Given this list of marker genes EPHB1, PAX2, CHRNB2, EPHB2, KCNA2, GLI3, here is a description of the gene set: species: Homo sapiens The process in which the anatomical structure of the optic nerve is generated and organized. The sensory optic nerve originates from the bipolar cells of the retina and conducts visual information to the brainstem. The optic nerve exits the back of the eye in the orbit, enters the optic canal, and enters the central nervous system at the optic chiasm (crossing) where the nerve fibers become the optic tract just prior to entering the hindbrain. Human Gene Set: GOBP_OPTIC_NERVE_MORPHOGENESIS